Given this list of marker genes Degs1, Degs1l, Plec, Myrf, Epb41l3, Sh3tc2, Ndrg1, Cxcr4, Abcd2, Akt2, Clu, Abcd1, Pten, Sod1, Fa2h (NCBI Gene Id 338521), Akt1, Prx, Pals1, here is a description of the gene set: Mouse Gene Set: GOBP_MYELIN_MAINTENANCE species: Mus musculus The process of preserving the structure and function of mature myelin. This includes maintaining the compact structure of myelin necessary for its electrical insulating characteristics as well as the structure of non-compact regions such as Schmidt-Lantermann clefts and paranodal loops. This does not include processes responsible for maintaining the nodes of Ranvier, which are not part of the myelin sheath.